The following is a description of a gene set: studied in species Homo sapiens Human Gene Set: ATGCTGC_MIR103_MIR107 Genes having at least one occurence of the motif ATGCTGC in their 3' untranslated region. The motif represents putative target (that is, seed match) of human mature miRNAs hsa-miR-103 and hsa-miR-107 (v7.1 miRBase)., and this is the list of marker genes: RUNX1T1, NDEL1, PPP6C, FBXO43, ST8SIA3, RASL12, BACH2, UBR3, RYBP, KIF21A, DSEL, NEXMIF, MED26, HLF, RNF38, ZBTB10, PSD3, PITPNA, SNTB2, SIX4, TWF1, SLC8A2, RNF125, RAD51C, RSBN1, AMMECR1, CACNA2D1, SUFU, ZBTB39, JAKMIP2, ZNRF2, RAI14 (retinoic acid induced 14), NFAT5, PPIP5K2, TLE4, ZCCHC2, SPATS2L, BTG2, HAPSTR1, AK2, YWHAH, RAB1B, BSDC1, GABRG2, BDNF, DCUN1D4, ZHX1, NRIP3 (nuclear receptor interacting protein 3), PALM2AKAP2, PLAG1, GPC6, MYB, NEDD9, CARM1, PURB, CRELD1, SEPTIN6, LCOR, MBNL1, SYNDIG1, CAB39, NF1, CAMKV, SYNJ1, ZC3H12B, FRMD4A, SH3BP5, BAZ2A, RET, FGF2, TSPAN5, PACSIN1, SLC26A10P, SIPA1L2, WNT3A, ZNF711, CDK6, BLMH, ANK1 (NCBI Gene Id 286), MTMR4, PHF20L1, MTSS1, UNC5A, C1QL3, ZFPM2, DLL1, TNRC6B, MARCHF3, PHF20, PHYHIPL, CLASRP, OGT, MEF2D, PIK3R1, BCL11A, TGFBR3, CC2D1B, ADAMTSL3 (ADAMTS like 3), CDK5R1, HMGA1, WASHC4, KIF3B, SLITRK1 (NCBI Gene Id 114798), MMP19, ZHX3, ARID5A, EPHA7, RASSF5 (Ras association domain family member 5), AXIN2, NKTR, TGIF2, ANO3, NR2C2, ITGA2, CHRD, GTPBP2, NFIA, SATB2, RBCK1, FBXW7, TMEM121B, HACD2, BTRC, FAM117B, RAB11FIP2, NSG1, TAF5, FCHSD1, PIEZO1, AGO4, SRGAP1, CFL1, KIF23, CPEB3, ZMYM2, WFDC2, ARMC1, RAP2C, LRRN3, ADGRL3, GLUD2, PCNX2, KIF5A, HIC2, FOXJ2, LRRC55, ERC2, EIF5, HTR4, LATS2, RBM24, PDE4B, NOVA1, SIK2, ADGRB1, CSNK1G2, PCGF5, SOWAHC, EVA1A, USP42, GREB1L, OTUD4, TBKBP1, BCLAF3, DICER1, HERC2, CHRM1, AGO1, DYNC1LI2, RSPO3, PPP6R2, AFF2, TPD52, ARMC8, ZC3H7B, ATL2, N4BP1, GLUD1, CELSR2, FAM81A, RGS4 (regulator of G protein signaling 4), CHST11, SUN2, SYT6, TBL1XR1, CNTNAP1, UBE2O, AGFG1, TRAM1, KPNA1, FURIN, GPCPD1 (NCBI Gene Id 56261), LRP1B, CDK14, DLG4, FNBP1L, LRP1, EIF4B, RAB10, CAPZA2, PRMT8, MIB1, FLOT2, GPATCH8, UBAP2, SNRK, PNN, NRP2, FAM171A1, ZIC1 (NCBI Gene Id 7545), AFF4, UBFD1, DNM1P46, DCBLD2, FAF2, MROH7, PDCD10